Given this list of marker genes AKR1E2, PYGM, AGL, GYG2, PHKG1, CALM1, PHKA1, PYGL, GAA, PGM1, PHKA2, PYGB, PHKB (phosphorylase kinase regulatory subunit beta), PHKG2, GYG1, here is a description of the gene set: Human Gene Set: REACTOME_GLYCOGEN_BREAKDOWN_GLYCOGENOLYSIS studied in species Homo sapiens Glycogen breakdown (glycogenolysis)